Given this list of marker genes Akap9, Mapk8, Trpv4, Git1, Ckap5, Clip1, Fes, Cav3, Numa1, Apc, Arl2, Nav3, Dctn1, Slain2, Pak1, Htr1a, Togaram1, Aurkb, Katnb1, Drg1, Met (NCBI Gene Id 194383), Psrc1, Rps3, Slain1, Rac1, Map1b, Cav1, Stmn2, Hspa1a, Hspa1b, Mapt, Spast, Ankrd53, Mecp2, Mapre1, Cdk5rap2, Pde4dip, Cdkn1b, Gda, here is a description of the gene set: Any process that activates or increases the frequency, rate or extent of microtubule polymerization or depolymerization. studied in species Mus musculus Mouse Gene Set: GOBP_POSITIVE_REGULATION_OF_MICROTUBULE_POLYMERIZATION_OR_DEPOLYMERIZATION